The following is a description of a gene set: Any process of the immune system that can contribute to the formation of immunological memory or an immune response based upon activation of immunological memory. species: Homo sapiens Human Gene Set: GOBP_IMMUNOLOGICAL_MEMORY_PROCESS, and this is the list of marker genes: IL23R, HLA-DRA, FGL2, ST3GAL1, CD46, TNFSF4, CD70, IGHE, TSC1, CD81, CD160, PCK1, HLA-DRB1, IFNL1, CD27, IL23A, BCL6, IL12B, TNFRSF14, IL12RB1, EBAG9